Given this list of marker genes CYBA, LAPTM5, SNX2, WAS, WASHC4, DAZAP2, GIT2, SERP1, LYN, HLA-DMB, LTA4H, HLA-DRA, SELL, MYD88, LAT2, HLA-DRB1, HLA-DMA, STAT6, SP110, ARPC3, RNASET2, CMTM6, SYK, PTPN6, SKAP2, ERP29, CNPY3, here is a description of the gene set: Neighborhood of LYN Human Gene Set: GNF2_LYN studied in species Homo sapiens Neighborhood of LYN v-yes-1 Yamaguchi sarcoma viral related oncogene homolog in the GNF2 expression compendium